Given this list of marker genes NCBP2AS2, ASB2, C2orf76, CYP17A1 (cytochrome P450 family 17 subfamily A member 1), ZNF365, C4orf36, DMAC1, PCDHB15, ESS2, NDUFA1, CMBL, GLB1, DDX4 (NCBI Gene Id 54514, DEAD-box helicase 4), PARP3, NHEJ1 (non-homologous end joining factor 1), MTMR4, GNS, FCF1, CIAO3, CSGALNACT1, DDHD1, NDUFS2, STAMBP, GALM, EIPR1, TMEM19, TUFM (Tu translation elongation factor, mitochondrial), GNPDA1, GSC2 (goosecoid homeobox 2), METTL16, NUP50, EIF5B, LHFPL6, B3GALT4, STXBP4, C1orf53, CRADD, EOMES, TSEN2, NBAS, COPS7A, CHST11 (carbohydrate sulfotransferase 11), WASHC1, METTL3, TOR1B, PAQR8, BRCA2, ADGRL3, CERT1, BSPRY, LAMB1, ZNF394, NEURL2, PAK6, SLC7A6, TANC1, PMF1, AGPAT2, DCP1B, DHTKD1, STAT4, SLC15A2, EIF3G, MPO, GPLD1, HIC2, VPS33A (VPS33A core subunit of CORVET and HOPS complexes), LRCH1, HVCN1, CAPN3, PTPMT1, DNAJC15, NR2C2AP, EYA3, YJU2B, AGL, NDUFS3, HEXIM2, SYT6, CLCN1, CHGA, DLL1, ZDHHC14, CCDC51, SPOUT1 (SPOUT domain containing methyltransferase 1), ATP1B3, TIMD4, ATMIN, LYPD6B, MFN1, LGR5, TGM2, THADA (THADA armadillo repeat containing), ATRAID, ARHGAP39, GRK4, CCDC17, P4HTM (NCBI Gene Id 54681), TMEM120B, RIOX2, FAM241B, BYSL, FBXO33, RLBP1, P2RY12, TRUB1, ALS2, GSTK1, TARBP2, PRDM15, TMEM231, VOPP1, ASH1L, CCDC73, DLEU7, PTPN3, TBX22, SPRTN, ABHD12, ERBB3, FSIP1, EID2, C6orf89, IFI35, C3, CD5L, ZNRD2, ATXN7, TRIM17, ANGPTL4, RGS17, RBPMS2, BTD, GPR84, B3GNT2, METAP1, LPP-AS2, ANAPC7, GSDMC, ELP1, NFKBIE, ADGRG5, CERKL, FAS, QTRT1, SPAG16, SWSAP1, AMZ1, TTC12, SNAPC3, HPDL, PRMT6, SLC6A14, LMAN2L, MMP11, ZSWIM7, TMEM267, DAP3, TNS3, DUS3L, SLC35G1, RBFA, TCFL5, HSPA1B, SEC22B, SFXN2, SLC25A29, ADGRF5, TUSC2, PISD, TBCCD1, SIAH2, CDYL2, TRMT61A, TSPO, EFNA5, PPARGC1A, PLEKHG6, USP24, DCAF11, H2BC18, SCML4, DCTN3, ATAT1, STYXL1, TRAIP, BRF2, RNF157, MFAP3, SKIDA1, SLC17A7 (NCBI Gene Id 57030), AS3MT, ZFP69, ZNF787, NEFH, MTX1, FANCF, ANGPTL6, HHAT, SLC25A2, here is a description of the gene set: from publication Pearce EL, Walsh MC, Cejas PJ, Harms GM, Shen H, Wang LS, Jones RG, Choi Y (PMID 19494812) Genes up-regulated in comparison of wild type CD8 effector T cells at day 6 versus those from mice defficient for TRAF6 at day 6. species: Homo sapiens Human Gene Set: GSE15750_WT_VS_TRAF6KO_DAY6_EFF_CD8_TCELL_UP CD8 T cells play a crucial role in immunity to infection and cancer. They are maintained in constant numbers, but upon stimulation with antigen undergo a developmental program characterized by distinct phases encompassing the expansion and then contraction of antigen-specific populations, followed by the persistence of long-lived memory cells. Although this predictable pattern of a CD8 T cell response is well established, the underlying cellular mechanisms regulating the transition to memory remain undefined. Here we show that TRAF6, an adapter protein in the TNF-receptor (TNFR) and IL-1R/TLR superfamily, regulates CD8 T cell memory development following infection by modulating fatty acid metabolism. We show that mice with a T cell-specific deletion of TRAF6 mount robust primary CD8 T cell effector responses, but have a profound defect in their ability to generate memory. This defect is CD8 T cell intrinsic and is characterized by the disappearance of antigen-specific cells in the weeks following primary immunization. Microarray analyses revealed that TRAF6-deficient CD8 T cells from early timepoints following immunization exhibit altered expression of genes that regulate fatty acid metabolism. Consistent with this, activated CD8 T cells lacking TRAF6 are unable to upregulate mitochondrial β-oxidation in response to growth factor withdrawal in vitro. Treatment with drugs that induce fatty acid oxidation enabled CD8 T cell memory generation in the absence of TRAF6. Remarkably, these treatments also increased CD8 T cell memory in wild type mice, and consequently were able to significantly improve the efficacy of an experimental anti-cancer vaccine.